Given this list of marker genes SLC1A1, here is a description of the gene set: part of: SLC transporter disorders There are two classes of glutamate transporters; the excitatory amino acid transporters (EAATs) which depend on an electrochemical gradient of Na+ ions and vesicular glutamate transporters (VGLUTs) which are proton-dependent. Together, these transporters uptake and release glutamate to mediate this neurotransmitter's excitatory signal and are part of the glutamate-glutamine cycle.<br><br>The SLC1 gene family includes five high-affinity glutamate transporters encoded by SLC1, 2, 3, 6 and 7. These transporters can mediate transport of L-Glutamate (L-Glu), L-Aspartate (L-Asp) and D-Aspartate (D-Asp) with cotransport of 3 Na+ ions and H+ and antiport of a K+ ion. This mechanism allows glutamate into cells against a concentration gradient. This is a crucial factor in the protection of neurons against glutamate excitotoxicity (the excitation of nerve cells to their death) in the CNS (Zhou & Danbolt 2014).<br><br>SLC1A1 encodes an excitatory amino-acid carrier 1 (EAAC1, also called EAAT3) and is abundant particularly in brain but also in kidney, liver, muscle, ovary, testis and in retinoblastoma cell lines. In the kidney, SLC1A1 is present at apical membranes of proximal tubes where it serves as a major route of glutamate and aspartate reuptake from urine. Defects in SLC1A1 are the cause of dicarboxylic aminoaciduria (DCBXA; MIM:222730), an autosomal recessive glutamate-aspartate transport defect in the kidney and intestine. Mutations that can cause DCBXA are R445W and I395del.<br><br>A defect in SLC1A1 is also implicated in schizophrenia 18 (SCZD18; MIM:615232). Schizophrenia (SCZD; MIM:181500) is a complex, multifactorial psychotic disorder characterised by disturbances in the form and content of thought, in mood, in sense of self and relationship to the external world and in behaviour. It ranks amongst the world's top 10 causes of long-term disability. At the neuropathological level, SCZD appears to be characterised by synaptic deficits, alterations in glutamate and dopamine neurotransmission and hypofrontality (a state of decreased cerebral blood flow (CBF) in the prefrontal cortex of the brain). Variations in the SLC1A1 gene can confer susceptibility to SCZD18. In the remote Pacific island of Palau, the risk of SCZD is 2-3 times the worldwide rate. In a 5-generation Palauan family, an 84kb deletion was carried by psychosis patients and proposed to increase the disease risk more than 18-fold for family members. studied in species Homo sapiens Reactome Pathway: Defective SLC1A1 is implicated in schizophrenia 18 (SCZD18) and dicarboxylic aminoaciduria (DCBXA)